Given this list of marker genes Lta4h, Gpx4, here is a description of the gene set: studied in species Mus musculus electronically inferred by orthology from the curated human pathway Reactome Pathway: Biosynthesis of aspirin-triggered D-series resolvins This event has been computationally inferred from an event that has been demonstrated in another species.<p>The inference is based on the homology mapping from PANTHER. Briefly, reactions for which all involved PhysicalEntities (in input, output and catalyst) have a mapped orthologue/paralogue (for complexes at least 75% of components must have a mapping) are inferred to the other species. part of: Biosynthesis of DHA-derived SPMs